The following is a description of a gene set: Human Gene Set: GCACTTT_MIR175P_MIR20A_MIR106A_MIR106B_MIR20B_MIR519D Genes having at least one occurence of the motif GCACTTT in their 3' untranslated region. The motif represents putative target (that is, seed match) of human mature miRNAs hsa-miR-17-5p, hsa-miR-20a, hsa-miR-106a, hsa-miR-106b, hsa-miR-20b and hsa-miR-519d (v7.1 miRBase). studied in species Homo sapiens, and this is the list of marker genes: SOCS6, SIK1, CNOT4, BICD2, LDLRAP1, RNF128, RAP2C, CACUL1, PRRX1, FOXJ2, CDC37L1, TNFRSF21, NUP35, SMOC2, LAPTM4A, CDKN1A, FJX1 (NCBI Gene Id 24147), DYNLT5, FCHO2, SERP1, KMT5B, NABP1, SQSTM1, NETO2 (NCBI Gene Id 81831), ZNF512B, TNRC6B, TBX3, SIPA1L3, CAPN15, CSRNP3, ANKRD9, LUZP1, NEUROG2, FAM117B, ZNF362, PTPN3, TNFAIP1, KLF12, USP3, NKIRAS1, ZBTB6, PLEKHO2, MARK4, CIC, CADM2, PDGFRA, TANC1, RAB5B, LMO3, MAP3K3, SLC22A23, RASD1, ZNF800, CCNT2, SENP1, OLFM3, SAMTOR, ANKRD50, KLHL20, NAGK, ZBTB9, CAMTA1, SUMF1, DCUN1D3, ATXN1, FNDC3A, APBB2, PCDHA3, SEMA4B, M6PR, KMT2D, REEP3, PAFAH1B1, NAA30, GRM7, OTUD4, CCNJ, SSX2IP, CCSER2, POLQ, FRMD6, PCDHA2, CSNK1G1, AGO1, GRHL2, ZFPM2, TNKS2, MAP3K2, MED12L, CAMK2N1, JPT1, SCML2, TLCD3A, WAC, CEP57, SLC1A2, MAP3K8, STYX, UBE2J1, ZBTB7A, PTGFRN (NCBI Gene Id 5738), FOXL2, ARHGEF11, ENPP5, KIF5A, FBXW11, TAL1, PRR16, ZNF236, ATG16L1, KPNA3, SET, PLEKHA3, TRAPPC14, RAPGEFL1, FAM13C, OGA, DDX11 (NCBI Gene Id 93260), WNK3, ORMDL3, CELSR2, HBP1, FOXA1, IP6K1, CCND1, MASTL, E2F5, NR2C2, MFAP3L, UBE2W, EEIG1, INTS6, SACS, RBL2, ITPRID2, L3MBTL3, SYAP1, TRPV6, TMEM127, KLF9, LRIG1, MIER2, INO80, COL4A3, TMEM168, BAHD1, RB1CC1, TMEM131L, CENPO, TRIP11, PHTF2, MIDN, CTDSPL2, TRPS1, KBTBD8, NEUROG1 (neurogenin 1), BTG3, MAPK4, SLC30A3 (solute carrier family 30 member 3), PCDHA10, RETREG2, CHD9, MARCHF8, PCDHA9, PPP1R21, RASGEF1A, C14orf28 (NCBI Gene Id 122525), EFNB1, PRRG1, MYO1D, TXNIP, AKTIP, DIP2A, BAMBI, FAM117A, OCRL, OSBPL5, NANOS1, PAK5, PPP3CA, BRMS1L, ARL4C, SLC40A1, GRAMD1A, ABHD2 (NCBI Gene Id 654057), SCRT2, CEP120, MORF4L1, CREBRF, FBXO21, TSPAN9, FBXL5 (F-box and leucine rich repeat protein 5), FAT2, NDEL1, FGD5, AFF4, TBC1D8B, NPAS3, HLF (HLF transcription factor, PAR bZIP family member), MAT2B, LHX8, C6orf120, ZBTB4, EPHA5, RSRC2, MAP7 (microtubule associated protein 7), SMOC1, RAB10, USP6, MMP24, CNOT6 (CCR4-NOT transcription complex subunit 6), CALD1, PCDHAC2, EMSY, RABGAP1, SRGAP3, BCL2L2, ANKFY1, JOSD1, IL25, PPP3R1, LIMK1, MINK1, KIF3B, SLC2A4RG, SLC2A4, BCL2L11, RAPGEF4, TRIM36, PFN2, SLC17A7, MYT1L, DUSP2, TLE4, PAFAH1B2, IGF2BP1, MTMR3, CERS6, DPYSL2, PPP6C, FGD1, PCDHA8, RNF6, SFMBT1, JRKL (JRK like), VANGL1, ARID4B, TP53INP1, ZBTB47, CREB5, ZFYVE9, TSG101, TGFBR2, SMAD7 (SMAD family member 7), SPRY4, EGLN3, ALX4, P2RX4, MCL1, VLDLR, EIF5A2, TIMP2, TNFSF12, PKIA, IKZF4, MYCN, CCNG2, KAT2B, RASSF2, DDHD1, NR4A2, CLIP4, SSH2, MAP3K11, ASF1A, MKNK2, VEGFA, SASH1, DPYSL5, ATP2B2, PCDHA6, TAOK2, BNIP2, TNRC6A, RHOV, EIF4H, BTBD10 (NCBI Gene Id 84280), PLEKHM1, PLAG1, PEX5L, SIKE1, STX6, MAPRE1, PIK3R1, CHD5, DYRK1A, TENT5C, AKAP13, DEDD, PHLPP2, PKNOX1, KLF11, ANK2, ARHGAP35, DUSP8 (NCBI Gene Id 1850), TET1, MAP3K12, HIF1A, RPS6KA5, FEM1C, SH3PXD2A, NBEA, RAB30, RASL11B, PTPRO, RBBP7, WDR37, SLC24A4, SLC4A7, ST6GALNAC3, EIF4G2, CMPK1, ZBTB18, PLAGL2, PLCB1, KDM2A, VPS26A, THRA, C2CD2, ANO6, PAPOLA, EZH1, GBF1, WDFY3, UBE2Q2, TSHZ3, CCND2, YPEL2, PCYT1B, TBL1X, ULK1, PPP2R2A, SPOPL, ACSL4, ZNF217, HDAC4, RGMA, SPTY2D1, PRR15, HMGA2, ZFYVE26, YES1, SLC6A9, PKD1, HYCC2, DNM2, ZDHHC1, JAZF1, LHX6, E2F3, GABPB2, KIAA0513, NIPA1, USP46, MECP2, MEX3D, GABBR2, RUNX1, KCNQ2, DNAJC16, CFL2, SRPK1, ANKRD28 (ankyrin repeat domain 28), PCDHA13, STAT3, SLITRK3, SNX16, PTEN, DMTF1, KIF23, GAN (NCBI Gene Id 8139), PHF6 (NCBI Gene Id 84438), PURA, SOX4, CYP26B1, RETREG3, PPP6R3, SINHCAF, AGFG2, GOSR1, TNFSF11, MAP3K14, SUCO, NPAS2 (neuronal PAS domain protein 2), GATAD2B, ZBTB41, DLGAP2, SYBU, KMT2C, BHLHE41, MAP3K9, ARHGAP1, NHSL3, RABEP1, EHD3, ARHGEF3, FURIN, EREG, TMEM64, E2F1, NPLOC4, LPGAT1, NR4A3, CNOT7, ARHGEF18, PREX1, PTHLH, IRF1, VSX1 (NCBI Gene Id 8198), SMAD6, ATG2A, ADAM9, ST8SIA2, PSD, KCNJ10, CA10 (NCBI Gene Id 769), ARID4A, EFCAB14, DCAF8, TMCC1, SORL1, PAF1, EFL1, AJUBA, PTPN4, LIMA1, CAMK2N2, BTBD7 (NCBI Gene Id 55727), SKI, CEP97, MTLN, ZNF367, YPEL4, PCDHA12, SEMA4G, CRIM1, SGMS1, ZNF25, SP8, CLOCK, ITCH, URI1, PCDHA4, PANX2, PCDHA1, ZHX2, PARD6B, TUSC2, SAR1B, TMEM50B, AHCTF1, ZNF652, TRIP10, BMPR2, STC1, DYNC1LI2, RSRP1 (NCBI Gene Id 57040), FNDC3B, RHOC, YTHDF3, DAZAP2, PLS1, CRK, CD69 (NCBI Gene Id 969), UBR5, UBE3C, FNBP1L, NHLH1, F3, ETV1, SS18L1, SERTAD2, ZNF532, FLT1, GIGYF1, SNX21, TNKS1BP1 (NCBI Gene Id 85456), GNB5, ZFAND4, ZDHHC9, FASTK, ELK3, PBX3, NRP2, S1PR1, DNAJB9, ARHGEF10, ATP1A2, MAP3K5, MAPK9, NEK9, ZNF704 (zinc finger protein 704), RAB11FIP1, UNKL, PKD2, PURB, HABP4, DERL2, ZNFX1, CAMTA2, RGL1, ITGB8, WEE1, PCDHA7, RAB22A, HAPSTR1, NPAT, PPP6R2, TRIM3, MKRN1, MAPRE3, EGR2, HAS2, DNAJC27, DCBLD2, RBL1, PCDHA11, DDX5, NBL1, AFG1L, STK38, SOBP, HECA, AKT3, SMAD5, BNC2, PGBD5 (piggyBac transposable element derived 5), OXR1, SRSF2, BCL11B, ZFP91, TOPORS, TMUB2, RSBN1, EPHA4, SMC4 (structural maintenance of chromosomes 4), GID4, ANKRD13C (NCBI Gene Id 81573), EPAS1, ATAD2, RPS6KA1, ATL3, DNAJB6, EPHA7, USP32P2, GAB1, FRMD4A, ARHGAP12 (NCBI Gene Id 94134), FOXJ3, PCDHAC1, OSR1, DENND10P1, KCNMA1, DENND10, PLXNA1, CC2D1A, TGOLN2, UBFD1, TWF1 (NCBI Gene Id 82712), RB1, NAPEPLD, CRY2, LDLR, PPARA, TBC1D9, RTN2 (reticulon 2), PCDHA5, HMGB3, QKI (QKI, KH domain containing RNA binding), NEDD4L, YOD1, LYPD6 (LY6/PLAUR domain containing 6), NCOA3, PHF1, KPNA2, RPS6KA3, NTN4, TP53INP2, NFAT5, XRN1, APP, USP32, ABCA1, SH3BP5, ZNF148, RRM2